Given this list of marker genes TRMT61B (NCBI Gene Id 55006), POP7, TRMO, TRMT2B, DUS1L, TRMT1, ELAC1, DTWD2, TRMT13, TYW5, QRSL1, TRMT61A, TSEN34, SEPSECS, ANG, THUMPD2, WARS1, QARS1, TRMT12, EARS2, MRPL58 (NCBI Gene Id 3396), IARS1, DUS4L (NCBI Gene Id 11062), VARS2, TRUB1, YARS2, TRMT9B, NARS2, VARS1, PTRH1, TYW1, DTWD1, TRUB2, TRMT1L, MARS1, RPP21, TARS1, PTRH2, TRPT1, PRORP, WARS2, CARS2, RPP25, METTL8, RPPH1, TRMT10B, RARS1, TRMT10C, ELAC2, PUS1, RPUSD4, CDK5RAP1, YARS1, AARSD1, GGT5, ETF1, METTL6 (NCBI Gene Id 131965), NSUN2, THG1L, DTD1, MTFMT, GTPBP3, SARS2, LCMT2, DUS3L, PTRHD1, TRMT10A, ALKBH8, TRNT1, THUMPD3, TARBP1, RPP40, METTL2A, AARS2, KARS1, TYW1B, DARS2, LRRC47, FARS2 (phenylalanyl-tRNA synthetase 2, mitochondrial), PRORSD1P, DARS1, BCDIN3D, GTDC1, FARSB, LARS1, NSUN6, LARS2, PSTK, TRIT1, GGT1, DTD2, NT5C3A, TRMT5 (tRNA methyltransferase 5), TRDMT1 (tRNA aspartic acid methyltransferase 1), GARS1, AARS1, CDKAL1, QTRT1, QTRT2 (queuine tRNA-ribosyltransferase accessory subunit 2), POP4, GATB, RARS2, RPP38, HARS2, CARS1, B3GNTL1, TARS2, FTO, PUS7, DUS2, IARS2, TARS3, FTSJ1, ALKBH1, PUS3, DALRD3, METTL2B, PARS2, NARS1, NSUN3, TYW3, POP5, TRMU, HARS1, TSEN2, TRMT2A, TRMT11, PUSL1, TRMT44, RPP30, MARS2, ANKZF1, RPP14, MTO1, PUS10, POP1, SARS1, EPRS1, GATC, METTL1, FARSA, here is a description of the gene set: Catalytic activity that acts to modify a tRNA. species: Homo sapiens Human Gene Set: GOMF_CATALYTIC_ACTIVITY_ACTING_ON_A_TRNA